The following is a description of a gene set: from publication Gautam P, Hamashima K, Chen Y, Zeng Y, Makovoz B, Parikh BH, Lee HY, Lau KA, Su X, Wong RCB, Chan WK, Li H, Blenkinsop TA, Loh YH (PMID 34584087) Human Gene Set: GAUTAM_EYE_IRIS_CILIARY_BODY_CILIARY_BODY_ENDOTHELIAL_CELLS Occular cell types curated from Gautam and Hamashima et al. Multi-species single-cell transcriptomic analysis of ocular compartment regulons studied in species Homo sapiens, and this is the list of marker genes: UNC119, ZNF578, SUN1, AP2A2, BCL6B, RAB1B, PRKD2, PLAA, CCNYL1, NOD1, KEAP1, XRN2, ARHGAP4, AUTS2, CREB3L2, RPS19, TGFBR3, RAB14 (RAB14, member RAS oncogene family), TUBA4A, RPS15A, MTX2, PPID, PRR5L, POLR3H, DNAJA2, HMOX2, GLTP, CISH, ACKR3 (NCBI Gene Id 57007), CDKN1B, WASL, CDK12 (NCBI Gene Id 51755), SCYL3, NDST1, CD2AP, TRIM47, PPIL1, ZNF302, ZC3HAV1, JAGN1 (NCBI Gene Id 84522), NAT9, PCDH11X, KMT5B, HSP90AB1, PKN1, ARHGAP31, RBBP5, RHOBTB1, SMYD5, IKBIP, EIF2AK1, TINF2, RPL36, ORMDL2, AIFM2, SELENOS, TMEM106A, TRAF3IP2, C1orf54, REXO4, GLRX, PKN3, CARS2, ZFP14, ARHGAP23, TREX1, FRMD4B, TMEM183A, PPP3CA, FAM174A, STEEP1, RALGAPA1, HCG18, EPN1, IL18BP, RASL11A, BZW2, SLC1A7, LBHD1, EIF4EBP1, TJP1, NSMCE1, USP14, ABHD17A, TMSB4X, NDUFB9, RNF213, PDSS2, CSNK2A1, MRPL42, SHE, EIF6, ATP5F1C, BRD4, ZMYM6, MLLT6, ISY1, PMAIP1, PLCB1, CUL2, STT3B (STT3 oligosaccharyltransferase complex catalytic subunit B), MRPS18B, RPS6KB2, TMEM205, CCDC88A, OGG1, PDCD6IP, SH3BP4, PCTP, SPR, HIP1R, PPP6C, DDX21, KHSRP, ADARB1, EPB41L4A, SLC19A3, TRAPPC8, ZNF575, ADA2, MED12, KIF3B, CROCCP2, EIF2S1, SREK1IP1, MCUR1, SNRNP40, CMC1, PDS5A (PDS5 cohesin associated factor A), ARSB, ROCK2, RIPK3, GOT2, RARS1, SRA1, NDUFB3, FAM114A2, DTX3L, HMGB1, MORC2 (NCBI Gene Id 22880), NFIA, CENPB, DHRS4L2, APEX1, IFNAR2, TNFRSF10A, KDM1A, ACVR2B, THUMPD2, IMPA1, CDH2, MRTO4 (MRT4 homolog, ribosome maturation factor), NCBP2, RILPL2, ANKRD13D, RELA, BCAT2, MLST8, CCT5, PDGFC (platelet derived growth factor C), HAGH, TRIM27, WTIP, CCDC86, EIF2B1, PTBP3, MYO1E, STX4, CSRP1, VPS26A, RPLP2 (NCBI Gene Id 6181), KXD1, HINFP, SETX, CRTC2, RBM42, ATP2A2, TASOR, NTRAS, MYO10, SBF2 (NCBI Gene Id 81846), LLPH, SUZ12, SKI, COPS4, KMT2C, TSG101, UBR1, TAP1, STK3, CASP3, SLC30A1, IFI44, SMG7, METAP1, ARMCX2, PSMD14, CNN2, CEP112, ICA1, MAGEH1, OSTF1, ARRDC1, RUVBL1, GCA, ARHGEF10 (NCBI Gene Id 9639), TESK1, PPP2R3C, PLOD3, MIR155HG, BPNT2 (3'(2'), 5'-bisphosphate nucleotidase 2), UBTD1, SYNJ2, PAPOLG, ELMO1, GARS1, FAM89A, SEMA6B, PAWR, VPS13C (vacuolar protein sorting 13 homolog C), SLC25A22, ATP6V1A, TMOD3, ZNF800, TSPAN17, ARHGEF7 (Rho guanine nucleotide exchange factor 7, NCBI Gene Id 8874), ATP11C, TRIM33, LY6G5C, ECH1, EWSR1, PDPR, ZDHHC9, CAPZA1, DNPEP, BYSL (bystin like), AP3D1, C17orf67, RBBP6, ARFIP1, SLC52A3, DYRK1A, PINX1, RPS28 (NCBI Gene Id 6234), MRPL3, BPGM, PSENEN, NAPG, TRMT10C, MGAT2, ATG3, PEX5, CISD1, LYL1, MNAT1, RPL10, FAT4, ILF3, FAM171B, RAB32, FN3KRP, SNAPIN, CDC42EP1, SLC43A3, ALKBH3, RELL1, RDH14, DLC1, PSMB8-AS1, MED13, BEND7, SNN, CPSF1, CTCF, MESD, NEMF (NCBI Gene Id 9147), COMMD2, PLEKHG1, HMGN4, SERPINA5 (serpin family A member 5), CSRNP3, ZNF595, KLF7, FNIP2, TLNRD1, RPS6, AGO3, SLC38A10, ZDHHC18, SAFB, ASAP2, PSMD2, PRDX4, BTBD7, IL15RA, SDCBP, ATXN2L, UHRF2, MBOAT7, PRXL2C, UIMC1, TMEM44, PPAN, ZNF503 (zinc finger protein 503), SLC35A4, SLC66A3, CNOT7, DDX5, LINC00987, COA4, MFSD10, PTPN11, PRR14, AGPS, ANGEL1, SEMA3A, SCN1B, BLOC1S5, POGLUT1, SRPRB, PPME1, FAM120C, CLDN10, ATF7, MAX, FAM241A, BRAF, USF3, PZP, SPTLC2, RPIA, IFFO1, SUPT5H, TMEM107, PTRH1 (NCBI Gene Id 138428), PPP1R35, TWNK, CCDC137, DENND2C, EVA1C, PLEKHB2, YTHDC1, CCM2, HIPK2, STAG1 (NCBI Gene Id 10274), ELK4, ARHGEF6 (NCBI Gene Id 9459), NAALADL1, DNAJC21, CTNND1, ARAP3, CTBS, SQOR, C1orf198, DUSP26, GNPAT